Given this list of marker genes ITGAM, AKIRIN2, CHID1, B4GALT5, MCEE, IFNAR1, KICS2, HHEX, CEP164, ZBP1, FIZ1, ZNF521, GYPC, NCCRP1, ESR1, CISD2, HPS5, EVI2A, APAF1, RBM43, MMP23B, FNDC3A, MRPL42, EMILIN1, AATF, ISG15, PXDN, CAND1, FAM118B, B3GALNT2, FRZB, RHPN2, BRD4, EFCAB2, PDCD7, GPATCH2L, NDST1, CD72, SLC15A4, BAHD1, OSTM1, DBF4, MOB3C, INPP5A, VEZT, DGUOK, APTX, NUDC, NME7, GPX3, USP18, ZHX1, PIN4, IFIT1B, IFIT3, KLHL22, CSGALNACT2, PFN2, UFSP2, MRPS10, NRP1, FKBP1B, ZNF260 (zinc finger protein 260), CAPRIN1, RNF213, CDC123, RNF135, SDHAF3, NT5C3A, NT5C, NDN, YAF2, PXK, RIPOR1, LUM, ZNF511, DCT, TIFA, PPA1, TMEM256, POP7, CDC37L1, C19orf38, ODR4, EPB41L1, SLC45A4, QTRT1, MRPS30, VMA21, C1orf122, INTS4, HLA-G, ARHGAP1, PEDS1, RALA, GPRASP3, MAPRE1, PSMG3, CYB561D2, ARHGAP30, GRN, ZUP1, ZWINT, ZFTA, GLT8D1, SMO, ORC3, IFIH1, MRPL21 (NCBI Gene Id 64993), CTBS (NCBI Gene Id 7811), PPIC, ARHGEF10, GTF3C6, HPCAL1, BCCIP, LARS2, ARMCX4, NAMPT, NFXL1, PRKRA, PTPRC, MOCS2, CWC27, PLEKHO1, TWF1, LIMCH1, ACO2, GNA12, SELPLG, RCC1L, DPP9, MCCC1, EXOSC9, PKIG, CHCHD7, CDK5RAP1, LETM1 (leucine zipper and EF-hand containing transmembrane protein 1), BORCS7, IL10RB, SFRP2 (NCBI Gene Id 6423), COQ7, FBLN7, ALKBH3, NRBF2, ARHGAP18, SCYL2, PMP22, TMPO, FSCN1, CPPED1, SLC30A5, GPM6B, CASP1, ANO10, EBNA1BP2, COASY, PDGFC, PIANP, GNG4, PRADC1, YRDC, IL15, AOAH, TTLL1, NFIC, ITSN1, USP38, RWDD1, DHX35 (NCBI Gene Id 60625), PIP4K2A, OGFRL1, TMEM106A, BTBD1, DHFR, NCOA1, MRPL27, RDH14, PLEKHM1, P3H3, MRPL30, CUL7, MPP1, ZNF655, QNG1, MEX3D, CCDC115, SNORD104, RBIS, CDH5, FCGR1A, LYRM2, IPO5, TMEM86A, ST7L, PLPP6, DPY30, LZIC, CASP4, PRXL2B, NDUFA2, here is a description of the gene set: Genes down-regulated in HMC-1 (mast leukemia) cells: stimulated with T cell membranes versus incubated with the peptide ALL1 and then stimulated with T cell membranes. Human Gene Set: GSE19888_NO_PRETREAT_VS_ADENOSINE_A3R_INHIBITOR_PRETREATED_MAST_CELL_TCELL_MEMBRANES_ACT_DN We demonstrate that the G protein Gi3 is the cellular target of the adenosine A3 receptor (A3R). By using a cell permeable peptide comprising the C-terminal end of Gαi3 fused to an importation sequence (ALL1) as a selective inhibitor of Gi3 signaling, we show that by coupling to Gi3, the A3R stimulates multiple signaling pathways in human mast cells, leading to upregulation of cytokines, chemokines and growth factors.Following contact with activated T cell membranes, endogenous adenosine binds to and activates the A3R, resulting in Gi3-mediated signaling. Specifically, the majority of ERK1/2 signaling initiated by contact with activated T cell membranes, is mediated by Gi3, giving rise to ALL1-inhibitable cellular responses. These results unveil the physiological GPCR that couples to Gi3 and establish the important role played by this G-protein in inflammatory conditions that involve adenosine-activated mast cells. We used microarrays to detail the effect of ALL1 on gene expression of HMC-1 cells activated directly by the A3 receptor, or by contact with activated T cell membranes. from publication Baram D, Dekel O, Mekori YA, Sagi-Eisenberg R (PMID 20190146) studied in species Homo sapiens